The following is a description of a gene set: Human Gene Set: GOCC_EUKARYOTIC_TRANSLATION_INITIATION_FACTOR_4F_COMPLEX The eukaryotic translation initiation factor 4F complex is composed of eIF4E, eIF4A and eIF4G; it is involved in the recognition of the mRNA cap, ATP-dependent unwinding of the 5'-terminal secondary structure and recruitment of the mRNA to the ribosome. studied in species Homo sapiens, and this is the list of marker genes: EIF4A1, EIF4E1B, EIF4G1, EIF4A2, EIF4E, EIF4E2, EIF4E3, EIF4EBP3 (NCBI Gene Id 8637), OTUD6B, EIF4G2 (eukaryotic translation initiation factor 4 gamma 2), EIF4G3, EIF4B, EIF4H